The following is a description of a gene set: Genes predicted to be targets of miRBase v22 microRNA mmu_miR_7030_5p in miRDB v6.0 with MirTarget v4 prediction scores > 80 (high confidence targets). studied in species Mus musculus from publication Chen Y, Wang X (PMID 31504780) Mouse Gene Set: MIR_7030_5P, and this is the list of marker genes: Pcdhga1, Tiam1, Slc6a8, Capn1, 1700030J22Rik, Scamp4, Nmnat2, Pou2f2, Leng8, Camk1d, Igfbp5, Pgpep1, Cyth1 (cytohesin 1), Gm7694, Gm2026, Pcdhgc5, Lamc3, Srrm4, Kif21b, Mbd6, Dennd1a, Atp2a3, Dusp3, Prr14l (proline rich 14-like), Tnfsfm13, 2310022B05Rik, Zfp385b, Mllt1, Ankmy2, Bcl2l1, Apba1, Tmem164, Pcdhga12, Mtcl2, Wnk4, Vamp2, Wfdc5, Kif5a, Hepacam, Ucn3, Septin5, Limk2, Sec62 (NCBI Gene Id 99913), Ptpa, Kif2c, Herpud1, Nrbp1, Txnl4a, Nf1, Gas7, Sphk2, Pacsin1, Gpx5, Zfp385a, Pxn, Fam107a, Klhdc3, Dnmt3a, Zfp703, Rph3a, Nfam1, Rpgrip1l, Bsn, Nek7, Cnot3, Cry2, Hspb7, Dpysl4, Nacc1, Pcdhga8, Elavl1, Tspan2, Mad1l1, Zfp593 (NCBI Gene Id 68040), Pgs1, Hip1, Slco2b1, Bean1, Prdm16, Zc3h18 (zinc finger CCCH-type containing 18), Sptb, Pcdhga10, Arf5, Pcdhgb8, Cacna2d1, Pcdhga2, Mpp7, Gm14308, Daam2, Rab3d, 2900026A02Rik, Brinp2, Tmt1b, Tpm2, Ngfr, Tbc1d16, Tmem104, Syndig1l, Chrna4, Cblb, Cbl, Limk1, Diras1, Ccdc82, Mical2, Elavl3, Igf2, Gng7, Rab35, Dhdds, Capn8, Vat1, Atxn1, Angel1, Sema5a, Frmpd3, Nos1 (NCBI Gene Id 76730), Trhde, Epha8, Hlf, Twf2, Pappa2, Snx17, Sox4, Ppp1r9b, Trim27, Castor2, Cyp2g1, Clstn1, Smarcd2, Gpd1, Rbm28, Pcdhgb7, Gm5938, Nova2, Mxd3, Pou2f1, Slc2a4, Zmiz1, Celf5, Smad2, Klrg2, Gprin1, Cabp2, Asic1, Tmem63b, Nectin2, Zfp983, Epb41l4b, Pcdhga3, Ccdc97, Oas3, Tnfsf13, Spindoc, P2rx7, Lmtk2, C1qtnf1, Crtc1, Sdccag8, Ttyh3, Fntb, Ube2q1, Adap1, Nipal3, Zfp58, Parvb, Mink1, Shisa7, Gm14296, Gm14434, Sox13, Zcchc3, Ctdsp1, Adgrl1, Nbl1, Tob2, Hsbp1l1, Scamp5, Mmab, Kcnj5, Tgif2lx2, Erf, Ppard, Tgif2lx1, Mlst8, Cops7b, Tcp11l1, Serpinc1, Ddx41, Cenpb (NCBI Gene Id 12616), Bak1, B3gnt6, Cacfd1, Hoxb1, Gnao1, Nxn, Pde4a, Fscn1, Spopl, Atg9a, Cntn2, Gm14322, Cacna1e, Tnrc18, Serpinf2, Spry4, Kdm5c, Scai, Zcchc24, Shisa6, Zfp710, Etnk1, Meis2, Pip5k1c, Xpo7, Spib, Celf3, Ephb4, Mef2d, Smarcd1, Gm14325 (NCBI Gene Id 329575), Api5, Kirrel3, Tef, Stat3 (signal transducer and activator of transcription 3), Rogdi, 2210418O10Rik, Kif18b, Pcdhga5, Kcnc3, Tpbpa, Map6d1, Foxo4, Xrra1, Pcdhga7, Fam78a, Carm1, Nfasc, Xylb, Arid1a, Pfdn1 (NCBI Gene Id 67199), Myrf, Hectd3, Ptgdr2, Cd82, Chdh, Pde1b, Pcdhga9, Rreb1, Vsx2, Tspan11, Creb3l2, Rcvrn, C1qtnf6, Manbal, Hsd3b6, Wdtc1, Zdhhc18, Kcnj10, Pcdhga11, Gmeb2, Trim3, Sox12, Mmp17, Iqsec3, Hectd4, Tes, Rasl10b, Hs6st1, Nherf2, Nav1, Ddb1, A4galt, Anxa7, Gm12185, Ctnnd1, Tulp1, Atxn7l3, Taok3 (TAO kinase 3), Gm4724, Zfp827, Tmem8b, Dok4, Itga3, Spock2, Elk1, Ywhae, Nkd1, Myl9, Pate3, Erv3, Nfic, Nfix, Entpd7, Pcdhgc3, Pitpnm3, Fbxo41, Bach2, Cyfip2, Barhl1, Rnf216, Kdm6b, S1pr3, AI597479, Sh3pxd2a, Eda, Smchd1